Given this list of marker genes MXD1, BHLHE40, GAL, PHLDA1, FOSL1, RASD1, PLK3, MPZL2, BCO1 (beta-carotene oxygenase 1), NAV2, EREG, MAP1B, TRIB1, PLEK2, ELK3, STRN3, SPRY4, KRT81, DUSP5, GOLT1A, HBEGF, EGR3, SLC7A11, LPAR6, CCN2, AREG, MALL (NCBI Gene Id 7851), ADGRG6, DUSP4, TNFRSF21, MAFF, STAMBPL1, ERRFI1, EGR1, CAPN8, RUNX2, CEMIP, DUSP6, ITGA2, RASGEF1A, LIF, REEP1, EPHA2, GEM, SHC4, MAP3K5, here is a description of the gene set: species: Homo sapiens HER2 is a tyrosine kinase receptor causally involved in cancer. A subgroup of breast cancer patients with particularly poor clinical outcomes expresses a heterogeneous collection of HER2 carboxy-terminal fragments (CTFs). However, since the CTFs lack the extracellular domain that drives dimerization and subsequent activation of full-length HER2, they are in principle expected to be inactive. Here we show that at low expression levels one of these fragments, 611-CTF, activated multiple signaling pathways because of its unanticipated ability to constitutively homodimerize. A transcriptomic analysis revealed that 611-CTF specifically controlled the expression of genes that we found to be correlated with poor prognosis in breast cancer. Among the 611-CTF-regulated genes were several that have previously been linked to metastasis, including those for MET, EPHA2, matrix metalloproteinase 1, interleukin 11, angiopoietin-like 4, and different integrins. It is thought that transgenic mice overexpressing HER2 in the mammary glands develop tumors only after acquisition of activating mutations in the transgene. In contrast, we show that expression of 611-CTF led to development of aggressive and invasive mammary tumors without the need for mutations. These results demonstrate that 611-CTF is a potent oncogene capable of promoting mammary tumor progression and metastasis. Human Gene Set: PEDERSEN_METASTASIS_BY_ERBB2_ISOFORM_1 Genes regulated in MCF7 cells (breast cancer) by expression of full-length and truncated (611-CTF) forms of ERBB2 at both 15 h and 60 h time points. from publication Pedersen K, Angelini PD, Laos S, Bach-Faig A, Cunningham MP, Ferrer-Ramón C, Luque-García A, García-Castillo J, Parra-Palau JL, Scaltriti M, Ramón y Cajal S, Baselga J, Arribas J (PMID 19364815)